Given this list of marker genes Mthfs, Dhfr, Mthfd1l, Gart, Qdpr, Fpgs (folylpolyglutamyl synthetase), Gch1, Atic, Folr1, Spr, Mthfd1, Pcbd1, Slc46a1, Pts, Pcbd2, Mthfsl, here is a description of the gene set: species: Mus musculus The chemical reactions and pathways resulting in the formation of any compound containing pteridine (pyrazino(2,3-dipyrimidine)), e.g. pteroic acid, xanthopterin and folic acid. Mouse Gene Set: GOBP_PTERIDINE_CONTAINING_COMPOUND_BIOSYNTHETIC_PROCESS